Given this list of marker genes ABCG1, ABCC1, ABCG4, ABCB11, ABCD1, ABCC11, ABCC3, ABCA12, ABCC4, here is a description of the gene set: Human Gene Set: GOMF_ATPASE_COUPLED_LIPID_TRANSMEMBRANE_TRANSPORTER_ACTIVITY species: Homo sapiens Enables the transfer of a solute or solutes from one side of a membrane to the other according to the reaction: ATP + H2O + lipid(in) = ADP + phosphate + lipid(out).